The following is a description of a gene set: studied in species Homo sapiens Human Gene Set: GOCC_STEREOCILIUM_MEMBRANE The portion of the plasma membrane surrounding a stereocilium., and this is the list of marker genes: PKHD1L1, MYO1C, CLRN2, USH2A, RIPOR2, ADGRV1, VEZT